The following is a description of a gene set: Human Gene Set: GOBP_NUCLEAR_PORE_ORGANIZATION studied in species Homo sapiens A process that is carried out at the cellular level which results in the assembly, arrangement of constituent parts, or disassembly of the nuclear pore., and this is the list of marker genes: NUP133, NUP153, NDC1, NUP54, SEH1L, NUP205, NUP107 (nucleoporin 107), NUP35, NUP93, TPR, AHCTF1 (NCBI Gene Id 442770), FXR1, RTN4, TMEM170A, NUP98